The following is a description of a gene set: Human Gene Set: GSE17721_POLYIC_VS_CPG_1H_BMDC_UP mouse primary BMDCs were stimulated with tlr ligands and gene expression changes were profiled on Affymetrix arrays from publication Amit I, Garber M, Chevrier N, Leite AP, Donner Y, Eisenhaure T, Guttman M, Grenier JK, Li W, Zuk O, Schubert LA, Birditt B, Shay T, Goren A, Zhang X, Smith Z, Deering R, McDonald RC, Cabili M, Bernstein BE, Rinn JL, Meissner A, Root DE, Hacohen N, Regev A (PMID 19729616) studied in species Homo sapiens Genes up-regulated in comparison of dendritic cells (DC) stimulated with poly(I:C) (TLR3 agonist) at 1 h versus DC cells stimulated with CpG DNA (TLR9 agonist) at 1 h., and this is the list of marker genes: SENP1, COA3, STK26, MAK (male germ cell associated kinase), PAPOLA, LMNB1, CELSR3, TMEM54, ATF2, CSNK2A1, PELP1, LCAT, PES1, SLC35C1, CEP152, KIF1A, NUDT16, NDUFAF1, GFI1B, EIF2AK2, ZNF841, FAM50A, EXOSC8, GINS4, OGFOD2, MTA1, RLBP1, NFX1, ERAL1, PREB, NFYB, MCM3AP, LIPT2, PSMG2, VPS9D1, DNAJC3 (DnaJ heat shock protein family (Hsp40) member C3), ATG16L1, SLC29A2, SNAPC2, ESR1, SAPCD1, NUDT16L1, RBM25, SLC15A5 (NCBI Gene Id 731387), FAM120A, RNF151, TRIT1, EIF5, SRRD, ZMYM5, FAM53A, TAF6, SEPTIN3, COX18, QNG1, SSR3, IKZF2, NAAA, METTL21A, GATAD2B, TSPAN8, IL12RB2, OR51B2, TOPBP1, SRP9, TCOF1, POLR2M, ARCN1, MATR3, PIGQ, ERCC8, ALG9, TOPORS, HCFC1R1, NFKBIL1, CALB1, SP6, SFRP2, KPNA6, INO80E, ZBTB7A, SYS1, DAB2, ERMP1, CACNG3, IREB2, SEPTIN8 (NCBI Gene Id 23176), EDRF1, EIF4H, FAU, MRPL9, DYNLL1, GBP2, RNF187, SCAF8, TEX264, C3orf38, SOCS7, RAC1, PIPOX, DDX50, RBM26, MRPS31, NPY1R, STX3, SLC37A4, SFSWAP, SMC4, BMS1, BRD4, IFNGR2 (NCBI Gene Id 3460), CLASRP, TRPV2, BCAS2, ELF2, SNTB1, RCC1L, NEK9, PPP1R12C (protein phosphatase 1 regulatory subunit 12C), C1orf43, DUT, ZBTB48, CDC5L, RALY, TRPS1, DDX19B, PPAN, SWSAP1, GPAM, F7, MEST, ODR4, LARP1, GLTP, CTNNBIP1, ING3, CSDE1, NIT1 (NCBI Gene Id 4817), PISD, ZNF329, ZNF808, RASA1, FBXO45, NUBP2, TNFSF8, RPS6KA1, PROKR1, ATP13A1, FANCF, OPN3, ZFP82, RPS21, FKBP4, ZNF707, RPS16, ENAM, COPS4, OSGIN1, GADD45G, CCND3, MYO18A, PPP1R21, SUDS3, COA5, PEX2 (NCBI Gene Id 5828), MMACHC, VAPA, SSBP1, DUSP6, PRKG2, TLR9 (NCBI Gene Id 54106, toll like receptor 9), MAU2, RAB3D, BATF, TMEM101, SMCO4, ALDH1B1, VPS26A, WDR43, YAF2, CETN2, RPLP1, IGF2R, ETAA1, MYO1F, AP1G2, PDCD2, CAD, USP36, MFSD8, OCA2, CD8B, BIN3, BLOC1S6, MAD2L1BP, MED8, TNRC6A (trinucleotide repeat containing adaptor 6A), CNOT3, PITX3, GREM2